The following is a description of a gene set: Absence or underdevelopment of the vermis of cerebellum. Human Gene Set: HP_APLASIA_HYPOPLASIA_OF_THE_CEREBELLAR_VERMIS Aplasia/Hypoplasia of the cerebellar vermis studied in species Homo sapiens, and this is the list of marker genes: BUB1, GDF6, TAF1, EBF3, DPH5, RERE, KIAA0586, SASS6, PDE6D, FKRP, MTM1, TMEM218, ACBD6, FAM149B1, ZIC1, CDC42, IMPDH1, NEK1, CC2D2A, RARS2, TULP1, ASXL3, WDR81, KIF21A, PPP1CB, SMARCA4, INTS1, ZEB2, ALX4, GJB2, PCYT1A, C2CD3, THOC2, USP9X (ubiquitin specific peptidase 9 X-linked), NUP88, PPP1R21, ATP9A, HYLS1, DPYSL5, CHD7, MED11 (mediator complex subunit 11), DHCR7, ROBO1, B9D2, RNF113A, RNU4ATAC, MAGEL2, ATN1, DPF2, NRAS, DPH1, SEMA3E, DYNC2H1, LRAT, TXNDC15, KPNA3, PRDM13, EVC, TCTN1, SOX4, KRAS, B4GAT1, TBCK, TBC1D24, COG1, ALG3, PLCH1, POMT2, NMNAT1, CPSF3, IFT80, ARID1A, ARHGEF2, PMM2, INPP5E, ARL3, TMEM138, FAR1, RPGRIP1, POMK (NCBI Gene Id 84197), ASXL1, PCGF2, TUBB4B, LARGE1, IFT172, NCAPG2, SOX11, TUBA1A, FOXC1, KIF7, ARID1B, BRF1, MID1, DOK7, MEF2C, VPS51, LAMA1, IQCB1, NUP37, ATP6V1E1, CDKN1C, SEPSECS, RAPSN, PLG, SRPX2, CEP120, TUBB, SMARCC2, MVK, SEMA6B, VPS35L, MKS1, IFT74, POMGNT2, CCDC22, RD3, PTEN, H3-3A (NCBI Gene Id 3020), OPHN1, WASHC5, GOT2, SLC18A3, OFD1, FRMD4A (NCBI Gene Id 55691), MAN2C1, TCTN2, POMGNT1, CSF1R, RAC1, FIG4, MRE11, CEP164, BICD2, MBD5, TOGARAM1, ADGRG1, CPT2, HRAS, CEP57, B9D1, L1CAM, BUB3, CRX, DDX3X, TSEN15, MAST1, NPHP1, MAB21L1, RPE65 (retinoid isomerohydrolase RPE65), ARID2, TSEN2, CCDC32, MDH1, HMBS, GJB6, HNRNPR, TBC1D20, EPG5, CEP104 (centrosomal protein 104), TUBB2A, KIAA0753, TMEM216, SLC25A24, NPHP3, TCTN3, GRM1, TMEM67, TMCO1, KNL1, TRAPPC9, PACS1, IGF2, DPH2, FKTN, CENPF, HNRNPH1, NSD1, ATP6V1B2, KCNJ13, ITPR1, EXOSC8, ESCO2, CBY1, ACY1, DYNC2I1, POGZ, PI4KA, GRIA3, EIF4A2, NSRP1, PPFIBP1, LETM1, HHAT, BMP4, GTPBP2, PIEZO2, SMARCD1, RAB3GAP2, FTO, PTF1A, PGAP2, PSAT1, BCOR, SMARCB1, EVC2, COG8, PAFAH1B1, RAB3GAP1, RAP1B, TAF4, FLVCR2, TSEN34, TMEM237, FGFR1, CLXN, MYOD1, TSEN54, WARS2, SYT2, AHI1, CWF19L1, RPGRIP1L, MACF1, DYNC2I2, B4GALT1, BUB1B, PIGN, MPL, TRRAP, ARMC9, AP1S2, SPATA7, IFT140, KCNQ1OT1, SACS, TRIP13, USP45, SLC25A19, LRRC32, DYNC1H1, GLI3, RDH12, PRKDC, APC2, FOSL2, KCNQ1, TMEM107, TUBB2B, SRD5A3 (steroid 5 alpha-reductase 3), PHGDH, RBM8A, ZNF423, RFX7, KIF5A (NCBI Gene Id 84710), ATP2B3, TMEM231, EXOC2, DENND5A, ATP6V1A, SMG9, B3GALNT2, PACS2, GUCY2D, ASNS, WDR73, CRB1, LAMB1, BLTP1, GEMIN4, DAG1, GPC4, POLR1A, CSPP1 (centrosome and spindle pole associated protein 1), SUFU, FAT4, CPLANE1, GMPPB, EBP, FDXR, LRPPRC, KATNIP, AFF3, SMARCE1, COQ4, LCA5, DCHS1, MUSK (NCBI Gene Id 4593), RAB11B, ARL13B, ATP6V0A2 (ATPase H+ transporting V0 subunit a2), CEP41, KIF14, VPS4A, RXYLT1, TUBB3, SLC35A2, LNPK, CNTNAP2, RBM10, POMT1, MAPKAPK5, ATR, PGAP1, TFAP2A, WLS, PIBF1, COL4A1, VLDLR, GPC3, NSUN6, POLR3A, WDR35, RAB18, CRPPA, TOPORS, CEP290, AIPL1, CDC42BPB, THG1L, PIGU